The following is a description of a gene set: from publication Zhong S, Zhang S, Fan X, Wu Q, Yan L, Dong J, Zhang H, Li L, Sun L, Pan N, Xu X, Tang F, Zhang J, Qiao J, Wang X (PMID 29539641) Human Gene Set: ZHONG_PFC_C1_OPC species: Homo sapiens, and this is the list of marker genes: CARD8, UBE2T, NUP37, MIS18BP1, USP1, CHTF18, PSRC1, RFC3, CDKN3, KIF14, BTG3 (BTG anti-proliferation factor 3), TMEM18, BARD1, TUBB6, KMT5A, H2AZ1, HS2ST1, ARHGAP11A, KPNA2, RNASEH2A, GUSB, KIF23, NRM, ITGB3BP, GAS2L3, LRR1 (leucine rich repeat protein 1), SKA3, TK1, NCAPG, MXD3, CENPN, PLEKHA5, SMC2, KIAA0586, BUB1, SHCBP1, CDC42BPA, RNFT2, DYNC2I2, HMMR, TUBGCP3, CKS2, CDC25B, CENPF, BRD8 (NCBI Gene Id 10902), HSD17B11, CDCA3, C21orf58, KIF22, SPDL1, PRC1, PBK, CCDC18, SPAG5, TUBA1B, DLGAP5, CNTLN, ESCO2, DHFR, KIF11, DIAPH3, BCAP29, NDC80, ARHGEF39, TROAP, CDC20, CKAP5, HJURP, KIF18A, ANLN, CEP135, TTK (NCBI Gene Id 7272), KIF4A (NCBI Gene Id 55595), ORC6 (NCBI Gene Id 23594), RAD51, ATAD2, CCNB2, CCDC34, CKB, POLQ, GTSE1, H4C3, TDP1, DEPDC1B, MKI67, NMU, ASH2L, HYLS1, PDLIM3, LGALS1, PCNA, NUDT1, PLK1, HMGN5, CCNB1, ARL6IP1, AURKA, HMGN2, RAD21, ASPM, NUF2, NDC1, SGO2, AK9, EMP3, CKAP2L, ASF1B, CENPE, RRM2, ENSG00000187951, G2E3, CCNY, CENPM, DEPDC1, NUSAP1, DDIAS, KIF20A, CDK5RAP2, C2orf69, CKS1B, RFWD3, EMC9, TGIF1, SCARA3, UBE2S, H2AZ2, KIF2C, CENPA, POLA2, CDC25C, PLK4, MAD2L1, KNSTRN, BRCA1, PIF1, FOXM1, MNS1, HMGB1, CENPU, KIF18B (kinesin family member 18B), S100A16, CENPW, HAUS6, POC1A, PPIF (peptidylprolyl isomerase F), ZWINT, VRK1, MELK, MTFR1, SPC25, TRIP13, REEP4, APOLD1, PHF19, CCNF (NCBI Gene Id 899), NCAPG2, CCNA2, ZNF83, NRAV, CDCA5, ESPL1, TUBA1C, ECT2, PARPBP, UBE2C, KIF15 (kinesin family member 15), PRR11 (NCBI Gene Id 55771), CEP152, MT2A, CEP55, AAMDC (adipogenesis associated Mth938 domain containing), FAM83D, RHEB, DTYMK, TOP2A, STON2 (stonin 2), AURKB, IFT22, HMGB2, KIFC1, KIF20B, FBXO5, OIP5, CKAP2 (NCBI Gene Id 55221), CDCA8, CDK1, SFRP2, NCAPD2, SCLT1, KCNE5, RNF26, CIP2A, FEM1C, VIM, TPX2, H2AX, MND1, BIRC5, FANCD2 (NCBI Gene Id 2177, FA complementation group D2), CDKN2C, TACC3, ANP32E, UHRF1, NCAPH, GIHCG, CENPC, PCLAF, GMNN, PIMREG, TMEM106C, MAP2K2, BUB3, CENPK, NEK2, SFR1, CCDC150, CDCA4, PTTG1, HMGB3, QSER1, TMPO, CHEK2, CDCA2, LDHA, RTKN2, RACGAP1, GINS2, DSN1, SMC4, TUBB4B, BUB1B, IQGAP3, FAM111A, KNL1, ACTN1, SGO1 (shugoshin 1), SKA1, RAD51AP1